The following is a description of a gene set: from publication Tabula Muris Consortium (PMID 32669714) Mouse Gene Set: TABULA_MURIS_SENIS_MAMMARY_GLAND_STROMAL_CELL_AGEING studied in species Mus musculus, and this is the list of marker genes: Tgfbr2, Tsc22d3, Cd34, Fcgrt, Ifngr1, Tnfsf12, Efhd1, Ddx5, Cebpd, Lpar1, Adprh, Tmem160, Rbms1, C1s1, Ndufb9, Tspo (NCBI Gene Id 12257), Smpd3, Etfb, Inmt, Ogn, App, Iah1, S100a11, Ecm1, S100a6, Cst3, Fhl1, Slit3, Entpd2 (NCBI Gene Id 12496), Dpep1, Serpinf1, Mcrip1, Igfbp5, Marcks, Cd81, Nbl1, Ramp2, Gstm1, Fbln2, Itgb5, Cbx3, Fkbp2, Ostc, Apoe, Vkorc1, Ndufb7, Steap4, Ndufs6, Pla1a, Dpysl2, Sec61b, Dynlrb1, Tmed10, Loxl1, Smim14 (small integral membrane protein 14), Smim11, Ndufa8, Drap1, Ablim1, Cd55, Mxra8, Scara5, Arid5a, Nenf, Atp5mf, Hmgn2, Triobp, Mcl1, Bnip3l, Nfia, Gsn, Tnfaip2, Ms4a4d, Ly6c1, Nfkbiz, Nr4a1, Elob, Fbln1, Tmem147, Ndufa4, Tle5, Sdc2, Socs3, Rex1bd (NCBI Gene Id 66462), Fbn1, Timp3, Anapc11, Abca8a, Col4a1, Krtcap2, Ehd2, Tmem50a, Lasp1, Tgfbr3, Chmp2a, Smpdl3a, S100a16, Lysmd2, Ndufb8, Lamp1, Kdm6b, Cpq, Spon2 (NCBI Gene Id 76474), Sertad1, Klf2 (Kruppel-like transcription factor 2 (lung)), Tmem219 (transmembrane protein 219), Anpep, Nucb1, Anxa3, Akr1a1, H2-D1, Mmp23, Ndufv3, Fosb, Mrpl23, Cd248, Crip1, Ndufa13, Scp2, C4b, Rhob, Tppp3, Selenom, Scara3, Tsen34, Srp14, Rabac1, Junb, Plxdc2, Pink1, Calm1, Arf5, Fis1, S100a13, Tmem134, Hsd11b1, Zfp36l1, Ntrk2, Cavin3, Swi5, Ptov1, Mtch1, Rer1, Ctdsp2, Ubl5 (NCBI Gene Id 66177), Emilin2, Selenow, Sparcl1, Cope, Tmed3 (transmembrane p24 trafficking protein 3), Romo1, Timp2, Anxa1, Rpn2, Uqcr11, Bloc1s1, Creb5, Mpc2, Tcf4, Actb, Cavin1, Klf4, Crtap, Ptms, Ier2, Cyba, Ahnak, Zfp36, Prss23, Adamts5, Fkbp8, Capg, Mgst1, Atf3, Mrps21, Slc43a3, Cygb, Hspg2, Atp5pf, Add3, Cox14, Selenop, Mrpl33, Gpnmb, Nfic, Emp3, Gpx3, Hint1, Dmkn, Id3, Tmem100, Ctbp1, Gnb2, Txnip, Srsf5, Anp32a, Park7, C3, Pdia3, Smim10l1, Camk2n1, Cirbp, Pltp, Gas6, Nfix, Dusp1, Sfn, Dpt, Pi16, H2-K1, Dpm3, Igfbp4, Irf1, Lrrn4cl, Cfb, Mtarc2, Rps28, Htra3, Mfap5, Pdlim2, Eln, Jund, Hmgb1, Pcolce, Blvrb, Ppib, Dctn3, Fus, Fos, Atp5me, Sgce, Lsp1, Fbln7, Etfa, Ndufa11 (NCBI Gene Id 69875), Uqcc2 (ubiquinol-cytochrome c reductase complex assembly factor 2), Cdkn1a, Prrx1, Itm2b, Ly6a, Gstt1, Myl12b, C1qtnf1, Serping1, Ifitm2, Fuca1, Fxyd1, Klf6 (NCBI Gene Id 97911), Mapk3, Lgals1, Igfbp6, Ppp1ca, Ypel3, Serpine1, Crip2, Ndufb4, Btg2, S100a1, Naxe, Rbm3, Sri, Angptl2, Dbn1, Tmem254, Clec3b (NCBI Gene Id 21922), Rnase4, Prdx4, Cdk2ap2, Ndufa3, Pcolce2, Cd9, Calm3, Tuba1a, Myadm, Rarres2, Smoc2, Ndufc1, Thbd, Egr1, Prnp, Ccl19, Fndc1, Prelp, Gm2a, Grn, Tuba1b, Ndufs7, Myoc, Ccl11, Ctdsp1, Cd47, Tnxb, Cuta, Gngt2, Tspan3, Cxcl14, Tprg1l, Rnf10, Ndufa5, Sbsn, Bsg, Cnpy2, Sod3, H2az2, Ptges, Il11ra1, Jun, Fxyd5, Ackr3, Gpx4, Hexa, Lamtor4, Ndufb10, Mxra7, Tmem256, Comt, Grcc10, Atox1, Hcfc1r1, Ddost, Pam, Tomm7, Nfib, Bcl7c, Lrp1, Gnai2, Dcn, Map3k8, Plac9, Ddah2, Ndn, Zfp385a, Osr2